Given this list of marker genes IL2RB, SGPP1, MGAT5, POU5F2, NEIL1, DBNDD2, GPR83, FBXO47, TUBGCP2, IQCE, EPSTI1, HEPHL1, RPL14, SLC35B4, PPP4R1L, MRPS18C, MICU1, ADHFE1 (alcohol dehydrogenase iron containing 1), CPPED1, RAPH1, ZC3HAV1, RUNX1, ECD, SDF4 (NCBI Gene Id 82832), ABCC4, RNF185, FOSL2, TANGO6, GRIA3, G3BP1, AXL, PBX2, CD99L2, PRR3, LMO3, USP10, MAML1, PLIN2, NT5E, DGAT1, ZXDC, GABARAPL1, ZDHHC9, TNFAIP3, STAT4, PTGER2, CFAP144P1, KRT222, PAK1, LTA4H, RDH11, CHST15, CEP41, DVL3, ADAM9, ABCA1, PENK, ACTR10, GTF2H5, SBF2, GYG1, DIS3L2, TIGIT, HELZ, SFMBT2, CD38, RNPEP, NFAT5, EIF2AK4, SLC6A6 (solute carrier family 6 member 6), MKRN1, STK24, TMEM14A (NCBI Gene Id 28978), PSMD11, UBAP2, FBRSL1, PRM1, CRADD, SCGB1A1, MAP2K4, USP28, SLC35B1, NSUN3, MCUB, RALGDS, SMARCD1, HEATR5B, ITPR1 (inositol 1,4,5-trisphosphate receptor type 1), MTSS1, GPAT4 (NCBI Gene Id 574440), CD44, DOCK2, CASP8, POU2F1, PDCD6, CYTH3 (cytohesin 3), ZSCAN29, KDM5C, FIZ1, CPT1A, DARS2, TPD52, STX18, GLIS3, PIGG, ZNFX1, CDK5RAP1, DGKH, PML, HYCC1, TLCD1, SNX12 (NCBI Gene Id 29934), RAB29, SLC22A5, CUL7, MIR128-1, EIF2AK1 (eukaryotic translation initiation factor 2 alpha kinase 1), KIF13A, SLC38A9, HS6ST1, PPME1 (protein phosphatase methylesterase 1), TXNL4B, LMAN2L, CD80, XPNPEP3, GLUL, ZFYVE26, FBXW11, WASHC3, PATL2, SCN3B, DHX58 (NCBI Gene Id 79132), PHLDA1, CFDP1 (NCBI Gene Id 10428), ZDHHC23, STRADB, SVBP (small vasohibin binding protein), PTPRJ, MRPS5, TUBB2A, ODC1, TPST1 (tyrosylprotein sulfotransferase 1), TRMT10A, BACH2, ANXA2, AFF3, IL12RB2, DUSP5, FCRL1, PGLYRP1 (peptidoglycan recognition protein 1), APLP1, P2RY14, GALM, CBX5, TRIM14, CDK6, PPP1R15A, AMPD3, RAB32, TBCEL, GPRC6A, PHLPP1, COG4, SLC25A12, TEX15, ACADSB, PAG1, PVR, DYM, here is a description of the gene set: studied in species Homo sapiens Human Gene Set: GSE37532_VISCERAL_ADIPOSE_TISSUE_VS_LN_DERIVED_TREG_CD4_TCELL_UP We identified Pparg as a major orchestrator of the phenotype of adipose-tissue resident regulatory T cells (VAT Tregs). To establish the role of Pparg in shaping the VAT Tregs gene profile and cell dynamics, Tregs from lymph nodes and visceral adipose tissue of mice sufficient and deficient of Pparg expression in Tregs were double sorted for microarray analysis. Genes up-regulated in T reg of aged mice: visceral adipose tissue versus lymph node. from publication Cipolletta D, Feuerer M, Li A, Kamei N, Lee J, Shoelson SE, Benoist C, Mathis D (PMID 22722857)